The following is a description of a gene set: Abnormality of mouth shape An abnormality of the outline, configuration, or contour of the mouth. studied in species Homo sapiens Human Gene Set: HP_ABNORMALITY_OF_MOUTH_SHAPE, and this is the list of marker genes: SF3B2, POLRMT, ATN1, PPP1R15B, ANKLE2, DHX37, SNORD116-1, OGT, SIN3A, BRPF1, RAD21 (NCBI Gene Id 5885), CCDC47 (coiled-coil domain containing 47), OCRL, KANSL1, GTPBP2, SETBP1, KCNK9, DNAJC21, FGFRL1, CNOT3, SLC9A6, SLC6A8, TMEM237, NOG, DPF2, C1GALT1C1, PIGV, ASXL3, ABCC8, SMARCD1, NCAPG2, TFAP2B, ZSWIM6, AGO2, PIK3R1 (phosphoinositide-3-kinase regulatory subunit 1), EFEMP1, WDR4, GK, NALCN, NFIX, KCNMA1, MED12 (mediator complex subunit 12), MBD5, MSL3, UBE2A, ESS2, PIGU, PIGO, MYMX, MASP1, CDK13, BUB1B, SMC5, AP1S2, ATRX (NCBI Gene Id 6475), MGAT2, DPYD, PDZD8, KDM4B, SETD5, MEF2C, DGCR8, PGAP2, ELN, PLOD3, ROR2, GCSH, PACS2, MED13L, EEF1A2 (eukaryotic translation elongation factor 1 alpha 2), ZNHIT3, PURA, PAK3, ADAM22, SLC35A2, ABL1, KAT8, KCNJ6, DCHS1, DGCR2, CRELD1, NKAP (NCBI Gene Id 79576), HDAC4, LIFR, LAMA2, GRIA3, HNRNPK, UNC80, DYRK1A (NCBI Gene Id 1859), PLXND1, SMC3, TBL1XR1, KMT2D, EXTL3, DENND5A, PIGW, COLEC10, DST, WNT5A, CTBP1, POGZ, RAB18, ATP1A2, TAF6, DPH5, PIGF, NONO, COLEC11, DIS3L2, CSNK2B, IGF2, IQSEC2, TELO2, CTCF, GPC4, INPP5E, FBXO11, PWAR1, WAC, SLC1A3, H4C11, NTNG2, MAFB, SNRPN, NDN, CDC42, GFM2, POLR3A, POMT2, TWIST2, GCK, TBC1D24, TCF4, LMBR1, BCAS3, AHI1, CDH11, SRCAP, CACNA1A, LEMD3, PDE4D, CAMTA1, COLQ, EHMT1, SNORD115-1, RAI1, KIAA0753, MED12L, SC5D, PARS2, PCLO, RAP1B, TCF20, GNB2, STRADA, SHMT2, ZC4H2, KIF15, LAMB2, ZMYM2, GRB10, NARS2, HDAC8, KDM1A, BAP1, VPS13B, IL1RAPL1, PRR12, ZEB2, DVL3, STAT3, EBP, SCNM1, SMC1A, TBCK (TBC1 domain containing kinase), AFF4, RPS23, RNU4ATAC, NRAS, NIPBL, KAT6A, KIF7, DEAF1, GBA1, H4C5, CHRNG, ECEL1, ATP1A3, PCGF2, DLK1, KCNJ11, TRIP12, CLTC, FAM149B1, DHX30, MYH3, ERCC2, PIGA, CACNA1C, MLXIPL, CDK5, ALX4, EIF2S3, EXT2, CHD8, KCNH1, TFE3, DVL1, ZPR1, RAC1, TASP1, H3-3A, SOX11, CCDC174, MYL11, PGAP3, PHF21A, HOXB1, RPS6KA3, SOX5, PPP2R5D, INTS1, SCN4A, LETM1, EBF3, RNU4-2 (RNA, U4 small nuclear 2), FZD2, PIGY (NCBI Gene Id 84992), FLII, PIGN, MEG3, POLA1, TBX1, NXN, NPAP1, AKT1, HSPG2, PACS1, TRMT10A, NOTCH2, GMPPA, HMGA2, MKRN3, SIM1, CHAMP1, FAT4, SON, PUS7, NEXMIF, RLIM, MTOR, BRAF, PIGL, BRD4, MAGEL2, AFF3, HS6ST2, STAC3, PIGT, NGLY1, PRKAR1A, DGCR6, ASH1L, HERC2, PPP2R1A, UBR1, CACNA1I, PRKAR1B, PIGQ, TET3, ATP6V1B2, NSD2, PIGG, ZBTB20, NOVA2, REV3L, FOXP1, ZNF407, INS, GLI2, PWRN1, TRAPPC9, HACE1, TUBB4A, WDR37, CPLX1, PPP1CB, OCA2, HRAS, RTL1, PDX1, CCDC88A, NELFA